The following is a description of a gene set: Mouse Gene Set: GOBP_DIGESTIVE_TRACT_MORPHOGENESIS studied in species Mus musculus The process in which the anatomical structures of the digestive tract are generated and organized. The digestive tract is the anatomical structure through which food passes and is processed., and this is the list of marker genes: Sox17, Hnf1b, Stra6, Egfr, Notch1, Wnt11 (wingless-type MMTV integration site family, member 11), Tcf21, Epb41l5, Wnt5a, Ctnnb1, Fgfr3, Npr2, Rbpms2, Six2, Trp73, Stx2, Vangl2, Hoxd13, Acvr2b, Nodal, Nckap1, Foxf1, Shox2, Agr2, Gli2, Cfc1, Fgf10, Pdgfra, Shh, Bcl2, Hoxa13, Trp63, Ovol2, Fgfr2, Nkx2-3, Smad2, Sfrp5, Id2, Gli3, Hlx (H2.0-like homeobox), Dact1, Hif1a, Tcf7l2, Foxp4, Pitx2, Sfrp2, Nipbl, Percc1, Tcf7, Sox10, Ihh, Sfrp1, Gata4, Smad3, Sox11, Ephb3